The following is a description of a gene set: Mouse Gene Set: TABULA_MURIS_SENIS_KIDNEY_KIDNEY_DISTAL_CONVOLUTED_TUBULE_EPITHELIAL_CELL_AGEING from publication Tabula Muris Consortium (PMID 32669714) studied in species Mus musculus, and this is the list of marker genes: Prkaa2, Pdcd4, Rpl7a, Wfdc2 (WAP four-disulfide core domain 2), Pnrc1, Reep5, F2rl1, Srsf11, Ncln, Rpl4, Rpl17, Rps2, Rnf10, Pde4b, Atp6v0a4, Rps24, Actb, Rpl12, Manf, Emb, Kap, Gas5, B2m, Hspa8, Sec14l1, Csrp1, S100a11, Rpl18a, Rpl36a, Cfl1, Rpl35a, Wsb1, Ifi27, Rps16, Dbndd2, Rpl23a, Ywhah, Eef1a1, Rbm3, Ywhaq, Calm1, Son, H2-K1, Ptma, Ly6e, Cd74, Gnas, Rab18, Tmem254 (transmembrane protein 254), Elf3, Rps23, Btg1, Rpl21, Ddit4l (DNA-damage-inducible transcript 4-like), Rps10, Slc34a1, Rplp1, H2-D1, Pigr, Zc3h13, Lgals3, Mt2, Rps6, Ndrg1, Scg5, Rps19, Rpl10, Rpl41, Mapt, Tmem178, Rps4x, Rpl9, Atp4a, Ppp1r1b, Mier1, Id2 (NCBI Gene Id 97802), Mtdh, Sox4, Nectin3, Rpl14 (NCBI Gene Id 67115), Rpl13, Tbc1d1, Rps12, Napsa, Idi1, Xist, Sh3bgrl3, Rpl13a, Csde1, Rps3, Rps8, Tuba1b, Rpl28, Rps3a1, Adgrg1, Spp1 (NCBI Gene Id 20750), Cited2, Rplp0, Rbm25, Zfp36l1, S100a10, Apoe, Rtcb, Tmsb4x, Tmsb10, Rell1, Lmo4, Rpl6, Ggnbp2